The following is a description of a gene set: Phase 4 - resting membrane potential Human Gene Set: REACTOME_PHASE_4_RESTING_MEMBRANE_POTENTIAL studied in species Homo sapiens, and this is the list of marker genes: KCNK4, KCNK9, KCNJ2, KCNK16, KCNK12, KCNK17, KCNK10, KCNK5, KCNK15, KCNK7, KCNK3, KCNK18, KCNK6, KCNJ12, KCNK1, KCNJ14, KCNK2, KCNJ4, KCNK13